The following is a description of a gene set: Human Gene Set: HP_LYMPHADENITIS Inflammation of a lymph node. species: Homo sapiens Lymphadenitis, and this is the list of marker genes: NCF2, RAG1, RAG2, RAC2, IRF1 (NCBI Gene Id 96501), CYBA, IRF8, MVK, RBCK1, CYBC1, STAT2, IL12RB1, RFX5, MYD88, CYBB, NCF1, ZAP70, CXCR4